The following is a description of a gene set: Human Gene Set: REACTOME_SENESCENCE_ASSOCIATED_SECRETORY_PHENOTYPE_SASP species: Homo sapiens Senescence-Associated Secretory Phenotype (SASP), and this is the list of marker genes: H2AZ2, H2BC21, UBC, H3C15, UBE2S, CDKN1B, H4C5, H2BC10, H2AC7, H2BC4, H3C7, EHMT1, H3C10, H2AC8, FZR1 (NCBI Gene Id 8855), H2BC3, RPS6KA1, CDK4, H2BC12, ANAPC10, H2BC1, H4C11, H2AC14 (NCBI Gene Id 8331), H2BC6, IL1A, H2AC19, H4C14, CDKN1A, H3C12, UBE2E1, H4C2, H2BC14, H2BC9, CCNA1, H3C14, UBE2D1, H2BC8, RPS6KA2, VENTX, ANAPC15, ANAPC5, H4C1, H4C15, H2AC4, H4C6, H4C8, H3C3, H3C6, CDC26, IGFBP7, H2BC12L, NFKB1, UBA52, H3C2, H4C9, H3C11, H2BC5, RPS6KA3, CDKN2C, H3-3B, JUN, H4C12, IL6, CXCL8, MAPK3 (NCBI Gene Id 5595), ANAPC11, H2BC13, H3C1, H2AB1, H4C4, H3-3A, FOS, RPS27A, H3C8, H4C16, CDC27, STAT3, CDK6, EHMT2 (euchromatic histone lysine methyltransferase 2), UBB, CEBPB, ANAPC7, CDKN2A, RELA, CDC23, H2AC20, CCNA2, H2AJ, H4C13, MAPK1, H3C13 (NCBI Gene Id 653604), ANAPC1, H2AC18, ANAPC4 (anaphase promoting complex subunit 4), ANAPC2, H4C3, MAPK7, CDK2, H2BC11, H2AC6, H2BC26, H2AX, H2BC17, CDC16, H3C4, CDKN2D, UBE2C, CDKN2B, H2BC15, H2BC7, ANAPC16